Given this list of marker genes Trim37 (NCBI Gene Id 72353), Vcp (NCBI Gene Id 269523), Dlgap1, Hdac6, Prkn, Ubd, Pmp22, here is a description of the gene set: Mouse Gene Set: GOBP_AGGRESOME_ASSEMBLY The aggregation, arrangement and bonding together of a set of components to form an aggresome; requires the microtubule cytoskeleton and dynein. studied in species Mus musculus